The following is a description of a gene set: Human Gene Set: HP_MANDIBULAR_PROGNATHIA species: Homo sapiens Mandibular prognathia Abnormal prominence of the chin related to increased length of the mandible., and this is the list of marker genes: DOCK3, MEG3, PCGF2, CAV1 (NCBI Gene Id 857), PIGV, GRIA4, RUNX2, ERCC4, ADAMTSL4, MESD, TNNI2, ACAN, KAT6A, HNRNPH1, SMS, NHS, PMM2, NEXMIF, PUF60, AIP, THUMPD1, UPF3B, KPTN, ACTB, PIGY, GJA8, GFPT1, KDM5C, SH3PXD2B, CACNA1G, HERC1, TONSL, SELENON, MYH3, AFF3, ERCC6, HERC2, SLC9A6, IQSEC2, LAMB2, RECQL4, SLC35A2, APC2, EHMT1, MBD5, SOST, TWIST2, DNMT3A, SLC12A2, KIF7, DEAF1, FBXW11, KDM6B, ANTXR1, TNFSF11, FOS, EXOSC5, CUL7, MYH8, ADAMTSL1, PDE4D, OCRL, HNF1B, CLCN4, MED25, POC1A, PTCH1, IARS2, LRP5, FGFR2, COLQ, ERCC8, RPS6KA3, PPARG, CTCF, SOX18, ZEB2, STAG2, TPRKB, MYOD1, EZH2, OPHN1, MEN1, ATAD3A, SLC4A10, KCTD1, RAB33B, HS6ST2, SRCAP, ATRX, U2AF2, STAT3, FLCN, PGAP2, PQBP1, SNRPN, OCA2 (OCA2 melanosomal transmembrane protein), PIGW, PTEN, AP4M1, PIGO, FOXG1, ACTA1, RNF113A, PYCR1, SLC25A24, SMAD4 (SMAD family member 4), ACBD6, GPC4, CDC42BPB, FBXO11, GJA1, CNTNAP2, IL1RAPL1, PRKAR1A, TBC1D7, GORAB, STEEP1, DDX59, ESAM, RPL10, P4HTM, CLIC2, ALG14, CLCN3, LRP4, GJA5, RFX7, SFRP4, ATP6V1E1, MYH7, FAM20C, DYM, CSNK2B, CUL4B, SETD2, MAN2B1, KAT5, H3-3B, SLC10A7, INSR (NCBI Gene Id 3643), SVIL, DLK1, CHRNE, FBN1, CHD8, SLC35C1, FLII, ASCC3, CDH11, TGFB1, NSD1, GLB1, MSTO1, FGFR1, H4C5, STT3A, TBC1D2B, RUSC2, KIF11, SUFU, AGA, FOXP1, PAX3, CRELD1, AP1S2, ATP10A, PIGL, PRKACB, RMRP, PCDHGC4, MED13L, KCNH1, RTL1, SLC6A17, SMPD4, AIMP2, SUZ12, PGAP3 (NCBI Gene Id 93210), IL6ST, CNOT3, MAF, ZFX, IDUA, SLC6A8 (NCBI Gene Id 6535), PTCH2, RNF125, TTN, IL11RA, CAVIN1, RAF1, H3-3A, APC, ATP6V0A1, ANKH, BSCL2, NSRP1, PLAAT3, FMR1, PRKG2, PTDSS1, GRIA3, NDST1, GPR101, TXNL4A, NFIX, AGPAT2, ERCC1, GPC3, GNB2, GNPTAB, MAGEL2, WDR62, UBE3A, POGZ, UBAP2L (ubiquitin associated protein 2 like), TBCK, GALNS, RAI1, LTBP3, MGAT2, PTPN11, DHX30, TAFAZZIN (tafazzin, phospholipid-lysophospholipid transacylase)